Given this list of marker genes Guca1a, Gucy2f, Gnat1, Rgs9, Rho, Rcvrn, Pde6g, Calm1, Nmt1, Gnb5, Cngb1, Sag, Rgs9bp, Pde6b, Gngt1, Cnga1, Camkmt, Ppef1, Fnta, here is a description of the gene set: electronically inferred by orthology from the curated human pathway This event has been computationally inferred from an event that has been demonstrated in another species.<p>The inference is based on the homology mapping from PANTHER. Briefly, reactions for which all involved PhysicalEntities (in input, output and catalyst) have a mapped orthologue/paralogue (for complexes at least 75% of components must have a mapping) are inferred to the other species. species: Mus musculus part of: The phototransduction cascade Reactome Pathway: Inactivation, recovery and regulation of the phototransduction cascade